The following is a description of a gene set: Any process in which a new genotype is formed by reassortment of genes resulting in gene combinations different from those that were present in the parents. In eukaryotes genetic recombination can occur by chromosome assortment, intrachromosomal recombination, or nonreciprocal interchromosomal recombination. Interchromosomal recombination occurs by crossing over. In bacteria it may occur by genetic transformation, conjugation, transduction, or F-duction. Human Gene Set: GOBP_DNA_RECOMBINATION studied in species Homo sapiens, and this is the list of marker genes: PSMC3IP, FANCM, SHLD2, CTBP1-DT, CNTD1, TP53BP1, CCR6, C1orf146, GINS2, RAD54L (NCBI Gene Id 8438), SHLD1, ERCC1, EP400, MEAF6, PELI1, MLH1, ENDOG, PPP4C, SYCP1, H1-1, SHOC1, HSPD1, BRCA1, TBX21, H1-7, RECQL, TREX1, RUVBL2, PAGR1, ATAD5, EPC2, RTEL1, ASTE1, APLF, BCL11B, APEX1, HDGFL2, SLX1A (NCBI Gene Id 548593), H1-8, INO80B, MCMDC2, TOP3B, RNF169, IL27RA, MRGBP, WRN, NBN, FIGNL1, EXOSC3, UBQLN4, SFPQ, PRKDC, MND1, EME2, RAG2, PARP1, HMGB1, XRCC6, KPNA1, SFR1, ZFYVE26, SWI5, ACTB, SWAP70, OOEP, MSH2, REC8, EXD2, CLCF1, PRMT1, POLB, INO80D, MCM6, ERCC5, NHEJ1, POLN, ACTL6A, RHNO1, NABP1, CDC7, TFRC, UBE2N, HUS1, H1-5, KMT5A, SAMHD1, AUNIP, RFWD3, SENP3, KHDC3L, MAJIN, PIAS4, XRCC3, XRCC1, TEX15, BRCA2, H1-10 (NCBI Gene Id 8971), FOXP3 (forkhead box P3), NSD2, ERCC2, MCM4, XRCC5, FBH1, INIP, INO80E (NCBI Gene Id 283899), INTS3, PALB2, SHLD3, LIG3, RNF126, NSMCE2, ING3, CENPX, CYREN, NFRKB, SETX, LIG4, NDFIP1, SLX4, ZSWIM7, NIPBL, POLM, HELB, RPA4, CD28, HROB, RMI1, RAD51C, MCM5, RAD21, SMARCAD1, TFPT, WRAP53, TERB1, RUVBL1, MCM8, ANKRD31, USP51, PSMD14, REC114, TOP3A, SANBR, VPS72, SMCHD1 (structural maintenance of chromosomes flexible hinge domain containing 1), ARID2, SMC5, ERCC6, MSH3, UNG, PTPRC, CREBBP, MCM3, H1-0, RAD21L1, TNFSF4, SWSAP1, C1QBP, AICDA, SLF1, ATM, IL4, SKP2, ERCC4, SUPT6H, RAD51D, GEN1, MSH5, PLK1, TIMELESS, AP5Z1 (adaptor related protein complex 5 subunit zeta 1), RAD54B, TERF2IP, KIN, KMT5B, TOP2B, TERF2, MCRS1, CSNK2A1, YEATS4, IHO1, NSMCE4A (NCBI Gene Id 54780), HDAC10, TGFB1, RNF8, STAT6, SETD2 (NCBI Gene Id 84184), HTATSF1, ZMYND8, DMC1, MAD2L2, SUPV3L1, BATF, RPA3, PRDM9, SMC6, EID3, NONO, H1-4, DMAP1, ACTR8, UHRF1, POLL, ACTR5, BRME1 (NCBI Gene Id 79173), TOP6BL, MCM2, RAD51AP1, PMS2, CGAS, WAS, RNF168, RADX, BLM, H1-2, THAP9, RNF212B, KDM4D, IL10, IL7R, H1-9P, TEX19, PARPBP, ZNF365, HMGB2, HELQ, FANCD2, PPP4R2, AP5S1, ZGRF1, INO80, RMI2, IL2, PGBD5, CCNB1IP1, PAXIP1, KMT5C, HMCES, KASH5, TONSL, CENPS, FANCB, SLX1B, CDC45, DCAF1, RECQL4, RAD50, MSH6, TERB2, KAT5, TRIP13, BARD1, UBR2, FUS, BRIP1, HUS1B, NSMCE3, RPA1, ABL1, CD40LG, H1-6, XRCC4, PCYT1A, MBTD1, TCF3, TERT, HSF2BP, MCM7, CHEK1 (checkpoint kinase 1), FAN1, POLQ, ZCWPW1, MCM9, SEM1, EXO1, TNFSF13, YY1, SYCE3, BRD8, RAD51B, FEN1, UBE2B, RAG1 (recombination activating 1), MMS22L, TOPBP1, APEX2, EXOSC6, NABP2, SLC15A4, RPA2, CD40 (NCBI Gene Id 958), RECQL5, KLHL15, HMGB3, ZSCAN4 (NCBI Gene Id 201516), LIG1, RAD51, NFKBIZ, RNF212 (ring finger protein 212), MEIOB, DCLRE1C, KDM1A, MSH4, XRCC2, WDR48, MEI4, MUS81, NSMCE1, RNF138, MRNIP, MORF4L1, RAD52, KPNA2, ANKLE1, MORF4L2, RIF1, HFM1, UCHL5, LEF1, PIF1, SLF2, TEP1, EME1, TOP2A, PARP3, MRE11, C14orf39, INO80C, MLH3, SIRT6, TRRAP, EPC1, SPO11, RBBP8, NUCKS1, REV3L, MAGEF1, ACTR2, GINS4, KLHDC3, SPIDR, H1-3, H2AX, CHD4, POGZ, TEX11 (testis expressed 11), BCL6